Given this list of marker genes ITGAV, PLEKHH2, ZEB2, PRKG1, NOTUM, DTWD2, CNTN1, SDC2, AFTPH, ARL6IP6, CBX3, FLRT3, ME1, AQP3, CEP120, SLCO5A1, CLVS2, C21orf91 (NCBI Gene Id 89755), REV3L, ZNF503, BOD1L1, DIAPH3, BRWD3, MMP16 (NCBI Gene Id 84257), MIER3, RC3H1, GCNT1, ODAPH, KRT28, TLCD4, NCKAP1, PRRC1, PGRMC2, SCML2, HIPK1, ZNF148, FGD4, PPP1R2, LMX1A, MYCN, PREX2, BMI1, IKZF2, PTGFRN, SMAD9, TTC19, TMTC3, TRPC1, ETF1, CCDC179, DUS4L, ACBD3, PLEKHG1, ACADL, TBCK, THSD7A, HECA, NUP50, DNAJB4, MMD, TRAM1, CA8, ASB3, C6orf120 (chromosome 6 open reading frame 120), CCDC117, LCTL, ZBTB44, EVI2A, ZDHHC15, RICTOR, SCN8A, ANKRD46, PTPRG, TRPC5, DAAM1, MIDEAS, SSR3, CDK6, HLTF, FIGN, GSTCD, ZNF747, LSAMP, DCDC2, BTF3L4, CISD2, S1PR1, ABI3BP, SPOCK3, PTPRR, SF3A1, COMMD3-BMI1, KIAA1586, NUMB, CAMLG, EEA1, NRG4, SETD2, TNFRSF21, ADGRB3, KLF10, MMUT (NCBI Gene Id 4594), METTL6, ZNF680, DOLPP1, ARMCX3 (NCBI Gene Id 51566), LCOR (ligand dependent nuclear receptor corepressor), ZNF326, CFL2, CLCN4, CTNNA3, SREK1, BTG2, LATS1, TFAM, RMND5A, RHPN2 (NCBI Gene Id 85415), CIAO2A, LACTB, RALA, PRP4K, BBS10, TMTC1, ZNF492, SAMTOR, DENND1B, FAM199X (NCBI Gene Id 139231), AHSA2P, TMEM167B, LARP4, GNAQ, MEX3D (NCBI Gene Id 399664), RO60, NOTCH2, SOX5, MEIS2, CCP110, SRSF6, RFC3, KPNA4, GATM, CEP350, ZNF792, RGS7BP, CCDC50, MTMR6, BTG3, ABCA5, PDZRN4, OAZ1, POU2F1, MAST3, SH3D19, LRRC7, MTF1, GABRA4, KLRD1, PRPF39, DDIT4, RNF149, CSNK1D, ACTN4 (actinin alpha 4), PRKAA2 (protein kinase AMP-activated catalytic subunit alpha 2), ZFAND5, SERINC5, MINDY2, FNIP2, GULP1, YIPF5, TOLLIP, FZD7, RAP2A, C5orf24, HDAC9, CAPN2, RAB27B, MAML1 (mastermind like transcriptional coactivator 1), MIER1, TRUB1, SENP1 (SUMO specific peptidase 1), RBBP8, TTC13, NOS2, RFX7, UBE2A, CCNB1, ADH5, EDIL3, NAV2, GRID2, ZBTB10 (zinc finger and BTB domain containing 10), SNX30, ATXN2, PRPF40A, GPC6, PCLO, LRRTM3, RASSF8 (NCBI Gene Id 11228), TMEM135, WDR7, FZD3, CCSER1, PITX2, PSMC2, ZBTB41, SPDYE1, MAST4, ITGB6, GOPC, ZBTB25 (NCBI Gene Id 7597), FAM221A, RPS6KA5, ARK2N, SACS, GABPA, IGSF3, SFMBT1, POLR2H, APPBP2, NR2C1, ZNG1A, NRXN1, IGF1, CD163, SCN1A, ZBTB20, CHRNA7, STEAP2, MECP2, PPP1R27, GPATCH11, COL11A1, KATNBL1 (katanin regulatory subunit B1 like 1), ANKRD10, LRP1B, NFAT5, PGAM1, AGTR1, LPP, CFAP44, STYX, FBXL3 (F-box and leucine rich repeat protein 3), ZNF486, KIF20B, ANAPC1, ZNG1B, PCDH11X, EPHA3, MAP9, EIF2AK2, GPR155, FSBP, URI1, ELL2, CARF, GRIP1, SLC4A7, BEND7, HOOK3, PPP5C, UGT8, SUMF1, METTL8, OGFRL1, SDE2, SCARF1, SLC30A5, ANKRD22, SNAP91, BNIP3, SAMD8, CBFB, PPP1R9A, SPATA6L, KL, ZNF608, C9orf40, CRIPT, ACAT2, MBNL2, RNF138, NEGR1, TFDP3, CRACD, SFT2D1, BBX (BBX high mobility group box domain containing), RHOQ, GRM5, CCNG2, ERC2, MBIP, LVRN, MGARP, ACBD5 (acyl-CoA binding domain containing 5), RORA, DIP2B, SMG1, GPALPP1, PAQR9, NFKB1, EPB41L5, ANKRD26, TXLNG, ATXN7L1, SECISBP2L, CFDP1, GOLGA6L2, DYNC1LI2, BCL2L2, SNX16, NEDD4L, PPEF2, MZT1, SCAMP1, SLU7, SPAG9, TRA2B, BRWD1, ZCCHC8, HOXD13, ZDHHC2, TPM3, HNRNPDL, NDC1 (NCBI Gene Id 55706), ZNF454, FGL2, SDF4 (NCBI Gene Id 82832), MAGT1, PCDH11Y, SANBR, MBNL3, CYBRD1, ZNF652, PDE4D, PTBP3, UTP3, GUCY1B1, HTR2C, IGF2BP3, TMEFF2, PAX5, ATP11A, NUP160, ZRANB2, C3orf38, TIFAB, RGPD4, CACNA2D3, WDR26, ACVR2B, RNF217, TP53INP1, HMBOX1, RESF1, GSE1, MFN1, CERS6, MED6, NUP54, PAPOLG, ZNF559, WAPL, UBA6, TMEM200A, GPR85, NTF3, RIMOC1, GTF3C3, RAP1A, GABPB1, PROK2, PDE1C, PHYHIPL, ALG11, PRKAG2, SKIDA1, SEC24A, LANCL1, PRELID2, SRSF3, CCNY, WDR47, RGPD6, MTFR1, DYNC1I2, GPD2, XPNPEP1, RRAGD, FZD5, TCF12, NAT1, ARRDC4, FAM133A, UEVLD, GCC2, TMEM255A, ZBTB11, MTA1, STXBP5, FGFR1OP2, ZNG1F, ARL13B, PDCD5, LMCD1, DHRS1, FAM135A, GRM7, TRIM2, RIC1, MDFIC, UNC80, SIX4, SRP9, DNAJB14, ZC3HAV1L, CAMSAP2, SESTD1, CACUL1, NAA30, ZDHHC21, A1CF, LIN7A, CD99, LACTB2, FOXG1, RGPD5, UGDH, MCF2L2, MFSD8, CHST9, DPY19L3, SMAD5, KLF7, ADAM30, C11orf87, ARFRP1, SLC24A3, PRKAA1, FNDC3B, AIDA, MIGA1, U2SURP, ANGEL2, SEC22C, RAB8B, CMPK2, ADAM22, SCN3A, GUCY1A2, CHN1, SLAIN1, DUSP7 (dual specificity phosphatase 7), ZNG1E, GLIPR1, EXOC5, TMEM65, ZNG1C, LRRC4B, JARID2, CCDC47, PPARG, KCNJ3, CLDN12, PPHLN1, ADAMTS1, SYTL5, KLF8, CSGALNACT2, PROSER1, TRIM9, AP1AR, RGPD8, B3GALT5, IKBIP, TMED7, FYB2, ARID2, RETREG1, FRMD5, SYNM, TBCA, AFDN, AK3, NDFIP2, FEM1C, ADAMDEC1, MAP4K4, HOMER1, GASK1A, SERINC3, FMNL2, GAPVD1, DEFA6, MARCHF6 (NCBI Gene Id 10299), here is a description of the gene set: Human Gene Set: MIR548AS_5P species: Homo sapiens from publication Chen Y, Wang X (PMID 31504780) Genes predicted to be targets of miRBase v22 microRNA hsa-miR-548as-5p in miRDB v6.0 with MirTarget v4 prediction scores > 80 (high confidence targets).